The following is a description of a gene set: from publication Iglesias A, Murga M, Laresgoiti U, Skoudy A, Bernales I, Fullaondo A, Moreno B, Lloreta J, Field SJ, Real FX, Zubiaga AM (PMID 15146237) Mouse Gene Set: IGLESIAS_E2F_TARGETS_DN E2F transcription factors are thought to be key regulators of cell growth control. Here we use mutant mouse strains to investigate the function of E2F1 and E2F2 in vivo. E2F1/E2F2 compound-mutant mice develop nonautoimmune insulin-deficient diabetes and exocrine pancreatic dysfunction characterized by endocrine and exocrine cell dysplasia, a reduction in the number and size of acini and islets, and their replacement by ductal structures and adipose tissue. Mutant pancreatic cells exhibit increased rates of DNA replication but also of apoptosis, resulting in severe pancreatic atrophy. The expression of genes involved in DNA replication and cell cycle control was upregulated in the E2F1/E2F2 compound-mutant pancreas, suggesting that their expression is repressed by E2F1/E2F2 activities and that the inappropriate cell cycle found in the mutant pancreas is likely the result of the deregulated expression of these genes. Interestingly, the expression of ductal cell and adipocyte differentiation marker genes was also upregulated, whereas expression of pancreatic cell marker genes were downregulated. These results suggest that E2F1/E2F2 activity negatively controls growth of mature pancreatic cells and is necessary for the maintenance of differentiated pancreatic phenotypes in the adult. Genes down-regulated in pancreatic cells from mice with double knockout of E2F1 and E2F2 compared to wild type. species: Mus musculus, and this is the list of marker genes: Prss2, Dmbt1 (NCBI Gene Id 270001), Cel, Syt3, Igf1, Gnmt, Loricrin, Itih4, Reg2, Reg3b, Reg3a, Nnt, H1f2, Mt1, Amy2a5, Mt2, Casp9